Given this list of marker genes Foxp3 (forkhead box P3), Il33, BC037156, Fcgr2b, Ndfip1, Lilrb4a, Ifnb1, Vpreb3, Zpbp2, Cd22, Tmbim6, Il13ra2, Prkdc, Siglecg, Parp3, Bcl6, here is a description of the gene set: species: Mus musculus Any process that stops, prevents, or reduces the frequency, rate, or extent of immunoglobulin production. Mouse Gene Set: GOBP_NEGATIVE_REGULATION_OF_IMMUNOGLOBULIN_PRODUCTION